Given this list of marker genes Tsc1, here is a description of the gene set: Reactome Pathway: Inhibition of TSC complex formation by AKT (PKB) electronically inferred by orthology from the curated human pathway This event has been computationally inferred from an event that has been demonstrated in another species.<p>The inference is based on the homology mapping from PANTHER. Briefly, reactions for which all involved PhysicalEntities (in input, output and catalyst) have a mapped orthologue/paralogue (for complexes at least 75% of components must have a mapping) are inferred to the other species. part of: MTOR signalling studied in species Mus musculus